Given this list of marker genes ATP6V1C2, UHMK1, MED13L, RNF13, PLEKHA1, TMED4, ZBTB20, HMGCS1, NAA15, UBL3, ZNF704, CLEC5A, SLAIN2, CFH, UBE2QL1 (NCBI Gene Id 134111), ZC3HAV1, BAHD1, PRRX1, FOXO3, LRP2BP, TBCEL, CRIPTO, SATB2, CLEC1A, FAM20B, ERP44, BNIP2, KDM2B, LRRC58, AP5M1, AHSA2P, SNRPD3, DSEL, DLST, CDHR3, ALG14, CDCP2, CD69, UBE3A, BRWD1, TCP11L2, TMEM25, SHANK2, PLCL1, DCUN1D5, NHLH2 (nescient helix-loop-helix 2), ZNF350, FMO3, TUT7, RGS2, TCEAL1, KCNIP1, ETS1, PSME3IP1, SMCHD1, GJA1, TENM1, ZMAT3, CHMP1A, SPHKAP, C6orf62, JAZF1, ZC3H14, UGCG, SGO1, CUL4B, MAN2B2, ANKRD28, KIAA1217, NFAT5, CLEC2B, SMAD4, LIMS1, CFHR1, C1orf74, BACH2, KICS2, PGM3, IVNS1ABP, KATNBL1, GUCY1A2, here is a description of the gene set: Genes predicted to be targets of miRBase v22 microRNA hsa-miR-6874-3p in miRDB v6.0 with MirTarget v4 prediction scores > 80 (high confidence targets). from publication Chen Y, Wang X (PMID 31504780) Human Gene Set: MIR6874_3P studied in species Homo sapiens